The following is a description of a gene set: Genes predicted to be targets of miRBase v22 microRNA mmu_miR_26a_5p in miRDB v6.0 with MirTarget v4 prediction scores > 80 (high confidence targets). Mouse Gene Set: MIR_26A_5P studied in species Mus musculus from publication Chen Y, Wang X (PMID 31504780), and this is the list of marker genes: Ccnj, Ubr3, Tmcc1, Arpp21, Tpsb2, Abl2, Chd1, Gm5592, Pcm1, Trib2, Hmga1, Crebzf, Pcnp, Tmc8, Pmepa1, Trp53inp1, Plod2, Abhd17b, Stx3, 1700006A11Rik, Ttc13, Mtfmt, Rpgr, Pak2, Clic5, Tub (TUB bipartite transcription factor), Phldb2, Col22a1, Dab2, Ddx3x, Ppp3r1, Grb10, Mapk6, Eif4g2, Mtx2, Etf1, Mab21l1, Parp10, Adamts6, Arhgef10, Pdgfra, Rcn2, Ezh2, Cttnbp2nl, Asxl1, Carmil1, Armcx2, Relch, Ice1, Sft2d3, Eri2, Dmrt3, Zfp518a, Zfp148, Usp3, Htr1a, Prr5l, Celsr1, Fbxl19, Ulk1, Homer1, Pcnx1, Chac1, Dlg5, Mex3c, Rhoq, 2510039O18Rik, Ccnjl, Slc30a5, Onecut2, Tnrc6b, Atad2b, Prkcd, Zfp462, Srcap, Hephl1, Ube2h, Bag4, Or13c7c, Tigd4, Serbp1, Cpsf2, Dnajc21, Dennd4a, Mmp16, Rgs4, Mtdh, Jarid2, Tsc22d2, Abcc4 (ATP-binding cassette, sub-family C member 4), Vdac1, Matr3, Bfar, Col1a2, Nampt, Bod1, Grk2, Tbc1d4, Plp1, Map2, Trim37, Plekhh1, St8sia4, Mtm1, Il6, Mxi1, Styx (serine/threonine/tyrosine interaction protein), B4galt4, Ddx17, Ccdc6, Dyrk1a, Tet3, Eif2s1, Thnsl1, Fam136a, Gna13, Scaper, Acsl3, Tmc7, Trappc6b, Acvr1c, Casz1, Cdk2ap1, Bhlhe40, D030056L22Rik, Fam53b, Adam17, Msantd1, App, Zbtb18, Arhgap21, Rest, Rgs6, Arb2a, Kcnj2, Abca5, Clgn, Crebrf, Sh3rf1, Ctnnd2, Hoxd13, Snn, Tmem68, Hoxc4, Tnrc6c, Ttpal, Pcdh18, Rps6ka6, Fa2h, Adam9, Elavl2, Dcaf7, Loxl2, Arpp19, Ypel1, Ppp3cb, Spred2, Togaram1, Frmd4b, Pdhx (pyruvate dehydrogenase complex, component X), Tet1, Eif5, Peli2, Pitpnc1, Twf1, Epb41l3, Nagpa, Klhl42, Cep350 (centrosomal protein 350), Zdhhc18, Ptpn2, Rnf6, Senp5, Rassf3, Fam222b, Slc22a23, Il36b, Depdc1b, Grhl3, Prkcq, Ubn2, Tmem184b, Dcdc2a, Pom121, Atp11c, Tlr3, AU040320, Ulk2, Hpgd, Larp1, Cemip2, Kmt5a, Ankrd63, Faim, Ep300, Ythdf3, Dapk1, Mras, Serpinb9b, Nup50, Ergic2, Cdk6, Ptgs2, Ppp1r15b, Rbm24, Mdn1, Mical3 (microtubule associated monooxygenase, calponin and LIM domain containing 3), Itga5, Rpl37, Bloc1s2, Rap2c, Anks1b, Sox5, Ctsl, Col19a1, Tab3, Gata5, Pfkfb3, Resf1, Clasp2, Fbxo48, Usp25, Cebpz, Phf6, Itprid2, Pwwp3b, Palm3, Gpsm1, Epha2, Erc2, Evx2, Rb1, Ccn2, Zfp608, Acbd5, Nudt11, Tbc1d30, Lnx2, Zdhhc6, Car12, Wnk1, Abi2, Adamts20, Map10, Ube4b (ubiquitination factor E4B), Tmed2, Palmd, Bcr, Arhgef26, Atf2, Fam98a, Slc25a20, Zfp410, Trpc3, Jag1, Magi3, Siae, Chfr, Srp19, Man2a1, Cnot6l, Pik3r3, Ark2n, Cipc, Pdcd10, Usp9x, Gm4884, Mfn1, Zfc3h1, Slc25a16, Plcb1, Naa15, Gm5114, Fgd1, Cdk8, Mier3, Cd200, Slc1a1, Pgr15l, Slc45a4, Tppp, Tob1, Zfp175, Frat2, Ttpa, Nabp1 (NCBI Gene Id 98468), Lsm12, Hoxa9, Slc7a11, Inhbb, Fhip1a, Camsap1, Chic1, Ube2g1, Zdhhc20, Tfap2a, Trpc4, Sema6d (sema domain, transmembrane domain (TM), and cytoplasmic domain, (semaphorin) 6D), Zfhx4, Lyve1, Epc1, Zswim6, Gmds, Catspere2, Kcnq4, Otud4, Slc38a6, Rspry1, Ccne2, Ap1s3, Kbtbd8 (kelch repeat and BTB (POZ) domain containing 8), Suz12 (SUZ12 polycomb repressive complex 2 subunit), Reep4, Hgf, Tmx1, Cfap43, Greb1l, Ssx2ip, Zfp275, Wnk3, Thap2, Pten, Skp2, Mme, Gmfb, Stk39, Nus1, Csnk1g1, Aspn, Adam19, Tet2, Esp36, Cep68, Chd2, Bcl7b, Abhd18, Psd3, Adam23, Stac2, Abhd5, Smad1, Zcchc24, Dennd1b, E2f7, Nap1l5, Pfdn4, Galnt7, Rgs17, Mex3b, Mat2a, Ube2j1, Arl4a, Tanc2, Tmem41b, Tnrc6a, Slc38a2, Hsbp1, Capn10, Vangl2, Pgrmc2, Pawr, Epc2, Ints2, Fbxo11, Cacna1c, Rcbtb1, Clec14a, Adm, Ugt8a, Rps6ka2, Hexim1, Nfe2l3, Hoxd8, Phf20l1, Pja2, Ssh2, Dmxl1, Strbp, Map3k9, Srgap1, Ndfip2, Kpna2, Anks1, Kpna6, Pcdh9, Aldh5a1 (aldhehyde dehydrogenase family 5, subfamily A1), Sbno1, Il20, Kctd18, Nceh1, Mfsd6, Stradb, Gsk3b, Zfp711, Sar1b, Bak1, Ep400, Slc19a2, Osbpl11 (oxysterol binding protein-like 11), Natd1, Nab1, Slc2a13, Col10a1, Ube2e2, Baz2b, Gad2, Mfhas1, Taok1, Car13 (carbonic anhydrase 13), Dock4, Dnmt3a, Sfmbt2, Amot, Ghsr, Mark1, Fbxo28, Mfsd14a, Tmem248